Given this list of marker genes TBC1D1, CALCOCO1, GSE1, NEUROD2, PTPRZ1, ARHGAP35, ID4, ZNF10, P2RY2, DISC1, BRCA2, GNAZ, PGM3, EPAS1, CNTN5, NEMF, MAPKBP1, ASAP2, TAC1, IP6K1, AGPAT1, PPP1R16B, MCF2L2, CXCL12, RAPGEF4, KRT37, FRMPD1, PKLR, NCAM2, NR0B2, EXOC6B, PLIN3, FAM50B, YJU2, CRYBB3, SATB2, ERLIN2, NR2E1, BRDT, SLC22A4, TRIM58, PDXK, IGFBP5, ALDH1A3 (aldehyde dehydrogenase 1 family member A3), TMEM47, UNC5C, CETP, RYR1 (NCBI Gene Id 906), MYO16 (NCBI Gene Id 23026), NOL3, RRM2, SLC22A14, CRP, MANBA, SFT2D2, CD8B, MAF, MERTK, SLC2A5, IGFBP6, FZD7, NFIL3, IMPDH1, GUCY1A1, MB, GAB2, SLC16A3 (solute carrier family 16 member 3), NID2, APBB1, IL10RA, FGF6, OPCML, CLIC5, DDO, HCRT, DBH, GATA6, H2AP, BMP10, NR1H4, RELN, H4C9, PRKACG, ORC1, PLD2, S100P, NUP62, TWIST1, RPS6KA1, GPR183, EXT1, B4GALT5, ANXA1, FMOD, KLC1, NFATC3, FOXF2, SGCG, LINC00837, ARHGAP26, SIRPB1, DSC3, LINC00588, HTRA2, FAAH, AGER, MYDGF, GPX4, PDE6H, ACRV1, LDOC1, GFI1, CDKN1C, ABCD3, GBX2, IFI30, SEMA3D, EHMT2, ATP7B, FBP1, TUBB4B, LY86, COL4A1, AQP5, ADCYAP1, PPARG, DIAPH2, SOX9, ANK1, PLXND1, MPZL1, GAB1, DOCK4, LRP1, BAP1, KCNJ2, EPYC, FOXO4, REG1CP, LSS, SRD5A2, PLPP3, LGR5, SPINT2, SOCS1, ALOX15B, SDC1 (NCBI Gene Id 6382), KRT32, IER2 (immediate early response 2), CCR3, SGCA, PAGE1, BRSK2, FOXD1, SPAG8, CD151, MTHFS, SLC19A1, PTPN3, MXRA5, APOA1, GPR135, CYP4B1, HLX, GP5, CDSN, ACKR1, EPO, LDAF1, KCNJ12, FOXA1, FCER2, SLCO1B1, EXPH5, CENPI, CD1A, EML1, NPAS3, SLC6A1, KRT8, TNR, TIMM17B, NR5A2, VIPR2, TMEM158, DDN, PPARA, CYP2B7P, TCP10L3, ANXA3, ARFRP1, PPP1R12B, RGS14, GABRR1, GNA15, LAMC1, CENPB, ATP2B4, RSAD2, here is a description of the gene set: from publication Anandasabapathy N, Victora GD, Meredith M, Feder R, Dong B, Kluger C, Yao K, Dustin ML, Nussenzweig MC, Steinman RM, Liu K (PMID 21788405) species: Homo sapiens Genes up-regulated in spleen dendritic cells: CD8- versus CD8+. Human Gene Set: GSE29949_CD8_NEG_DC_SPLEEN_VS_CD8_POS_DC_SPLEEN_UP To understand the functional relationship between brain dendritic cells (brain DCs) and other myeloid cells, we compared the gene expression profile of m/chDCs to that of bone marrow monocytes, brain microglia and classical spleen CD8+ and CD8- DCs. In order to obtain enough brain DCs for mRNA extraction, we expanded brain DCs with in vivo Flt3L treatment before purification.